Given this list of marker genes Cggbp1, Homez, Slfn5, Dph2, Bicd1 (BICD cargo adaptor 1), Ctsc, Ppp2r5d, Serpine1, Vps54, Zmym6, Diras2, Tceanc (NCBI Gene Id 279696), Glyctk, Zfp260, Galnt2, Ppp2r3a, Slitrk2, Ggh, Bfar, Cenpa, Ptdss1, Heatr5a, Ppp1r16b, Eif3j2, Adamts9, Olfm3, Zfyve26, Adrb3 (adrenergic receptor, beta 3), Smg1, Nkain2, Tppp, Tab3, Inip, Lysmd3, Srpra, Gtf2a1, Zyg11b, Polr1e, Nemp1, Sugt1, Eif3j1, Jag1, Rnf111, Pamr1, Mkx, Mstn, Usp37, Mcoln2, Cnnm1, Sdccag8, Wnt2b, Stum (NCBI Gene Id 96945), Gpr155, Taf1, Fat3, Rreb1, Itgb7 (NCBI Gene Id 16421), Bckdk, Tlnrd1, Slc17a2, Dsc3, Reep3, Arih1, Mblac2, Gp1bb, Arhgap32, Bmt2, Lrfn5, Kbtbd2, Psmd9, Scml2, Zfp867, Cd59b, Armcx2 (armadillo repeat containing, X-linked 2), Pnoc, Ccdc125, Cdh3 (cadherin 3), Fhdc1, Pwwp2a, Lmtk2, here is a description of the gene set: studied in species Mus musculus Mouse Gene Set: MIR_3470B Genes predicted to be targets of miRBase v22 microRNA mmu_miR_3470b in miRDB v6.0 with MirTarget v4 prediction scores > 80 (high confidence targets). from publication Chen Y, Wang X (PMID 31504780)